The following is a description of a gene set: studied in species Homo sapiens Genes having at least one occurence of the motif GTAAGAT in their 3' untranslated region. The motif represents putative target (that is, seed match) of human mature miRNA hsa-miR-200a* (v7.1 miRBase). Human Gene Set: GTAAGAT_MIR200A, and this is the list of marker genes: UBR3, SUZ12, RBFOX1, NAMPT, PCGF5, PLPP3, DLK2, HCN4, NSD2, HMGB1, QKI, TRMT1L, UBE3A, KMT2E, NR4A1, AMMECR1, UBFD1, ARPP21, SGK1, NOVA1, PAX6, PURB, KCNS3, IPCEF1, SHPRH, PAPOLG, SP100, HNRNPR (NCBI Gene Id 10236), DLC1, UBQLN2, NHS, RAB1A, NFIA, RANBP3, HTR2C, FGF13, GAN, ARMC1, FURIN, KLF9, TMSB4X, POU4F2, SLC39A14, PAFAH1B1, BICRA, CHD7, SP3, FOXD1 (NCBI Gene Id 2297), SRSF6 (NCBI Gene Id 6431), DYRK1A, NSG2, FZD1, IPO7, FLRT3